The following is a description of a gene set: Activation of the Mitogen activated protein kinase (MAPK) cascade following Toll-like receptor (TLR) stimulation enables innate immune cells to rapidly activate cytokine gene expression. A balanced response to signals of infectious danger requires that cellular activation is transient. Here, we identify the MAPK phosphatase Dual specificity phosphatase-1 (DUSP1) as an essential endogenous regulator of the inflammatory response to LPS. DUSP1-deficient (DUSP1-/-) bone marrow derived macrophages showed selectively prolonged activation of p38 MAPK and increased cytokine production. Intraperitoneal challenge of DUSP1-/- mice with LPS caused increased lethality and overshooting production of IL-6 and TNF-alpha. Transcriptional profiling revealed that DUSP1 controls a significant fraction of LPS-induced genes, that includes IL-6 and IL-10 as well as the chemokines CCL3, CCL4 and CXCL2. In contrast, the expression of the important mediators of endotoxin lethality, IFN-gamma and IL-12, was not significantly altered by the absence of DUSP1. These data together demonstrate a specific regulatory role of DUSP1 in controlling a subset of LPS-induced genes that determines the outcome of endotoxin shock. Genes down-regulated in untreated spleen: DUSP1 knockout versus wildtype. from publication Hammer M, Mages J, Dietrich H, Servatius A, Howells N, Cato AC, Lang R (PMID 16380512) Human Gene Set: GSE3565_DUSP1_VS_WT_SPLENOCYTES_DN species: Homo sapiens, and this is the list of marker genes: RPS3, TCF12, DUSP6, RPS26, SESN3, RHOH, TLR1 (NCBI Gene Id 7887), IKZF1, CD27, TOX, ZNF512B, CCDC28B, KAT2A, CD2AP, RALGPS2, GPR146, GDF10, PPAT, TCP11L2, EIF4A1, PDK1 (NCBI Gene Id 5163), HDAC4, EIF4G1, VIPR1, RPL22, IL6ST, TRIB2, TFRC, TRIM25, RAPGEF6, TCF7, ACSF2 (NCBI Gene Id 80221), CTNNBL1, ADD3, DPH5, AMPD1 (adenosine monophosphate deaminase 1, NCBI Gene Id 270), RPS10, PIK3C2A, LRRC42, RAPGEF4, EIF4B, FILIP1L, GNL3, DZIP1, ETV3, TANC1, GPATCH4, MPP1, KLHDC2, PATJ, STT3B, PITPNM2, EEF1B2, TSPAN13, GSTT2, ADGRG5, SREBF2 (NCBI Gene Id 6721), FAM78A, RAB3IP, PLAC8, ACTN1 (actinin alpha 1, NCBI Gene Id 87), RPL8, HDAC7, RBM38, DAPL1, RGS10, LEF1, CD3D, QTRT1, WDR12, ITGAE, TOP2B, ST6GAL1, FOXO1, TIMM9 (NCBI Gene Id 26520), EEF2 (eukaryotic translation elongation factor 2), PACSIN1, TBL1X, PCCB, RRAS2, SELL, SMC4, RASA2, GNAS, EYA2, ABLIM1, USF2, MYB, IFT80, BICDL1, ID3, RPL18, CMAHP, LBH, TUBB2A, MAP4K4, SRF, TREML2, ING1, MYBBP1A, RTP4, ACVR1B, CCNE1, FCHSD2, HOOK1, MGST2, F2RL1, CNP, SNHG1, DDX21, EXT1, GRK6, PELI1, N4BP2, ARHGAP9, NPC2, DUSP10, PIP4K2A, MTHFD1L, DPP4, TMEM131, RABGGTB, PRKD2, DGKA, RNF213 (NCBI Gene Id 79398), SATB1, SH3PXD2A, SHISA5, SLC14A1, NSG2, ST8SIA1, PTBP1, PIGQ, NOP58, LTB, SELENOP, NME1, SLC16A5, KBTBD11, TIMP2, PLEKHO1, RCN3, SIPA1L1, RNF144A, CCR9 (NCBI Gene Id 2851), USP28, IKBKE, PCBP1, MBNL2, INPP4B, MTSS1, SHMT2, MYC, IDH2, XRCC6, EVL, ARHGEF1, CD69, RPS6KA1, MDN1, RPLP0, TCF20, CD7, DNMT3A (DNA methyltransferase 3 alpha), FBL, RPL36A, ADD1, ITPKB, SIDT1, RPL31, RPL36, RPS19, TNFSF8, CARMIL2, CCT5, TET1, IFNGR2, SLAMF6, UBE4B